Given this list of marker genes SLC22A1, SLC23A2, STRA6, SLC44A4, SLC27A1, SCARB1, LRP2, SLC19A1, SELENON, SLC19A2, SLC25A19, SLC5A6, SLC19A4P, RBP4, SLC46A1, SLC47A1, SLC19A3, SLC23A1, ABCC5, SLC22A2, GC, here is a description of the gene set: The process in which a vitamin is transported across a membrane. A vitamin is one of a number of unrelated organic substances that occur in many foods in small amounts and that are necessary in trace amounts for the normal metabolic functioning of the body. Human Gene Set: GOBP_VITAMIN_TRANSMEMBRANE_TRANSPORT species: Homo sapiens